Given this list of marker genes FGF16, STRADB, CCNT1, MAPK8IP1, RGS14, DBNDD2, ECT2, NPRL2, APOE, RIPK3, SIRT1, CDKN1C, LCP2, NLRC5, STOX1, CLSPN, STK11, CIMAP3, RTRAF, CCNE2, ERN1, WNT5A, CALCA, PIK3R5 (NCBI Gene Id 23533), CDC37, SFN, FGR, TPX2, ADAM17, ALS2, SPDYA, CENPE, CARD10, TNFRSF10A, XRCC6, TRAF4, TAB2, ZFYVE28, HMGA2, PRKCH, PIH1D1, MAP4K2, TRIB3, PRLR, TARBP2, LAT, MAP2K1, PIK3CG, JAK2 (NCBI Gene Id 3717), RASIP1, GADD45A, PTK6, CDK5R2, ZNF622, FGF18, AGAP2, JTB, FGFR1, PTPRJ, TRAF6, TCIM, INCA1, RALB, CDKN3, PYCARD, TSPYL2, IGF1 (insulin like growth factor 1), DIRAS3, YWHAG, VPS25, FLT1, PTK2B, SYNPO2, SYAP1, DIRAS2, RBL1, TSG101, COPS8, HNRNPU, AIDA, SASH1, CAMKK2, SERPINB3, RASSF2, MAP3K7, RAP2B, ADAR, ADCYAP1, EMP2, NEK10, MAP3K10, APC, ABL1, S100A12, MVP, RAPGEF2, RASGRP1, MAP3K5, SNF8, CDC6, TLR6, CEACAM1, PIBF1, RBL2, GPRC5A, PPIA (peptidylprolyl isomerase A, NCBI Gene Id 5478), PIM1, PIK3R6, GSKIP, MST1R, CCDC88A, CCNT2, IRGM, PRKN, TRAF2, NHERF1, SNX9, LMO4, PILRB, MAP3K11, STK38, DRD4, HLA-DRB1, CCNK, ACP4, CHMP6, FBN1, CACUL1 (NCBI Gene Id 143384), DUSP1, SRCIN1, HIPK3, LDB2, SERTAD1, ARHGEF5, HEG1, CD74, EZH2, CASS4, DIPK2A, HGS, STRADA, NPM1, TIGAR, MACROH2A1, MRNIP, LILRA5, NEDD9, FGF2 (fibroblast growth factor 2), SNX6, GAS6, PRKCD, DSTYK, EEF1A2, TRIM27, TNF, PKMYT1, BCCIP, AGT, KIF14, MT3, CORO1C, ETAA1 (NCBI Gene Id 54465), CEP85, LTF (NCBI Gene Id 4057), ADIPOQ, GPRC5B, EREG, CDK5RAP1, CAB39, WARS1, PAQR3, CDK12, XRCC5, MAP3K4, RAP2C, TPD52L1, MIDN, RAP1A, PTPN1, DYNAP, CARD14, DDR2, FLT3, CDKN1B, UNC119, CDKN2A, PRDX3, PDGFB, LEP, DEFB114, TENM1, CD4, AKT1S1, TNFRSF10B, PPM1E, ADCY8, MMD2, TRIB2, RB1, DUSP7, ITGB1BP1, TRIB1, CRIPTO, ABI1, DNAJA1, HERC5, GTF2H1, CSF1R, SMG8, TAF7, NRG1, CDC25A, CDKN1A, ERRFI1, MAP2K2, ZGPAT, CD300A, FIRRM, MAP2K3, DIRAS1, CEMIP, DOK7, CIB1, FGF1, RHOA, ELANE, PTPRC, TAOK3, BLM, CAMK1, PAK2, SOCS5, LYN, MEN1, TOM1L1, PTK2, LATS1, ZFP91, TNFSF15, ADARB1, NPPA, ZNF16, PSMD10, CCNY, PTPN22, PDCD10, UVRAG, THY1, CEP43, KSR1, IFNG, CCNG1, TFAP4, ERBB2, ANGPT1, CHI3L1, CDC25C, TLR3, MST1 (macrophage stimulating 1), SOCS4, CDK5RAP3, LATS2, CHP1, SRC, DEPTOR, CDK5R1 (cyclin dependent kinase 5 regulatory subunit 1), PKIA, LDB1, MMD, GCKR, PDGFRB, PDCD4, MYCNOS, here is a description of the gene set: Any process that modulates the frequency, rate or extent of kinase activity, the catalysis of the transfer of a phosphate group, usually from ATP, to a substrate molecule. Human Gene Set: GOBP_REGULATION_OF_KINASE_ACTIVITY studied in species Homo sapiens